Given this list of marker genes PLAAT4, IFIT1, CXCL10, HLA-A, HLA-DRB1, C1S, HLA-DQB1, MX1, SOD2 (superoxide dismutase 2), UBE2L6, SAA1, IFITM3, TAP1, OAS1, TNFSF10, CD74, HLA-DRA (NCBI Gene Id 7930), HLA-F, HLA-DPB1, IFI27, HLA-DQA1, ISG15, IFI6, TYMP, IFIT3, PARP14, IFI44L, PLSCR1 (phospholipid scramblase 1), IFI44, HLA-B, PARP9, HLA-E, IFI35, ISG20, IFITM1, GBP1, WARS1, IFIT2 (interferon induced protein with tetratricopeptide repeats 2), LAP3, PSMB9, HLA-DRB5, HLA-DMA, BST2, STAT1, HLA-C, HLA-DPA1, PSMB8, GBP2, C1R, B2M, here is a description of the gene set: from publication Gavish A, Tyler M, Greenwald AC, Hoefflin R, Simkin D, Tschernichovsky R, Galili Darnell N, Somech E, Barbolin C, Antman T, Kovarsky D, Barrett T, Gonzalez Castro LN, Halder D, Chanoch-Myers R, Laffy J, Mints M, Wider A, Tal R, Spitzer A, Hara T, Raitses-Gurevich M, Stossel C, Golan T, Tirosh A, Suvà ML, Puram SV, Tirosh I (PMID 37258682) Genes upregulated in subsets of cells of a given type within various tumors In this study, an extensive analysis was conducted to define meta-programs (MPs) capturing intra-tumor heterogeneity across a spectrum of tumor types. The approach utilized non-negative matrix factorization (NMF) to analyze each cell type separately within individual tumor samples. This involved the analysis of malignant cells, macrophages, fibroblasts, endothelial cells, epithelial cells, T-cells, and B-cells. NMF was executed with varying parameter values (K=4, 5, 6, 7, 8, 9), thereby generating 39 programs for each cell type per sample. Each NMF program was summarized by the top genes based on NMF coefficients.\nRobust MPs were then delineated for each cell type using a set of stringent criteria, including recurrence within the same tumor, similarity to programs in other tumors, and non-redundancy within a tumor. Subsequently, these robust NMF programs were clustered (per cell type) based on Jaccard similarity, leading to the identification of MPs associated with each cell type.\nTo enhance the quality of the MPs, a refinement steps were undertaken, involving the removal of MPs suspected of reflecting low-quality data (with an overrepresentation of ribosomal proteins or mitochondrial-encoded genes), single-study inclusion, or similarity to miss-annotated cell types. studied in species Homo sapiens Human Gene Set: GAVISH_3CA_MALIGNANT_METAPROGRAM_17_INTERFERON_MHC_II_1